Given this list of marker genes SELENOH, PGAP6, TMEM268, DGKA, FBLN2, C5AR1, TLR9, ZC3H7A, CBR1, ENDOG, U2SURP, SUSD6, CRBN, PROS1, ACAA2, CFH, CEPT1, FYN (NCBI Gene Id 2534), ANXA11, ACOT13, BUB1B, LY86, AKAP12, ABHD8, GZMA, NCK1 (NCBI Gene Id 4690), UTRN, NECAP2, ITGB7, RIN1 (Ras and Rab interactor 1), ACRBP, BRCA1, RBM15, HLA-B, TWIST2, PPARD, BCLAF1, TMEM209, IQGAP1, OTX2, EVI2B, CARMIL1, SP4, SLC30A1, ADISSP, CHD4, LPIN3, CD274, PLK2, PRR15, SLC25A28, UBAC1 (UBA domain containing 1), PISD, CADPS, LOXL3, SH3BP4, KLRK1, ATP13A2, EEPD1, LPXN, BABAM1, FUCA1, SUB1, ADAM23, RNF214, KRTDAP, BATF2, CPPED1, KALRN, RABEPK, ACRV1 (acrosomal vesicle protein 1, NCBI Gene Id 56), RNH1, DIAPH1, EPHX1, RNF115, INPP5D, ATP10A, TPX2 (TPX2 microtubule nucleation factor), CDC42SE1 (CDC42 small effector 1), SERPINF2, LCE3B, ARHGAP31, TPRA1, BCL6, BRD4, CCNI, TAPBP (NCBI Gene Id 6892), TEPSIN, DGLUCY, TOX4, RMDN3, NIPAL2, MYL11, VPS72, CYSLTR1, ENTPD1, DDX60, PTTG1, CD300A, TOR3A, NCAPG2, GBP6, SMIM14, MYBPH, BDH1, OCIAD1 (NCBI Gene Id 54940), AVL9 (AVL9 cell migration associated), HM13, MGST2, DNAJC8, TPST1, EWSR1, EMC8, SVBP, RBMS1, MAP4K1, ESPN, TM2D2, AIG1, DUSP11, DOCK8, GRAMD2B, HDAC1, UBL3, MORC3, RASA2, DMAP1, NDRG1, SGK1, NFIA, ENDOD1, MXD4, PCDH7, VGLL4, SLC15A2, C19orf53, RBMS2, CASP9, SESN3, UGDH, POLR3C, PRPF38A, RLBP1, PLXNB2, PAX4, CCL4, B3GNT8, RCC2, CHRNA5, ABCG1, PRSS16, TPK1, TJAP1, BOC, DTD1, RYR1, COMMD5, B9D2, KLF3, GP1BA, LTB4R, PKIB, DBR1, RIPOR1, CTRL (NCBI Gene Id 1506), ASB11, ARHGEF7, CHST15, DNASE1L3, FZD5, RFC2, CAMK1D, DIO2, SPDL1, POLB, PLXDC1, WBP1L (NCBI Gene Id 54909), PIP5K1C, APAF1, HACD4, PRCP, ATP5IF1, SNW1, RHOV, MED11, RAB13, NANOG, SORL1, TMTC4, DNAJC15, TNFSF10, TMCO3, UPF1, CRAT, KCNA7, SERTAD1, PRR14, CERT1, CACUL1 (NCBI Gene Id 143384), here is a description of the gene set: mouse primary BMDCs were stimulated with tlr ligands and gene expression changes were profiled on Affymetrix arrays Genes up-regulated in comparison of dendritic cells (DC) stimulated with poly(I:C) (TLR3 agonist) at 8 h versus DC cells stimulated with CpG DNA (TLR9 agonist) at 8 h. studied in species Homo sapiens from publication Amit I, Garber M, Chevrier N, Leite AP, Donner Y, Eisenhaure T, Guttman M, Grenier JK, Li W, Zuk O, Schubert LA, Birditt B, Shay T, Goren A, Zhang X, Smith Z, Deering R, McDonald RC, Cabili M, Bernstein BE, Rinn JL, Meissner A, Root DE, Hacohen N, Regev A (PMID 19729616) Human Gene Set: GSE17721_POLYIC_VS_CPG_8H_BMDC_UP